Given this list of marker genes Ptprj, Trpv4, Csf1r, Cx3cl1 (NCBI Gene Id 58173), Ccr7, Slamf1, Tnfsf18, Mstn, C3ar1, Cmklr1, Mdk, Il34, Thbs1, Akirin1, Rarres2, Ccl2, Ccl21a, Ptk2 (NCBI Gene Id 14083), Csf1, Mapk3, C5ar1, Cxcl17, Mapk1, Trem1, Ccl5, here is a description of the gene set: Any process that increases the rate, frequency or extent of macrophage chemotaxis. Macrophage chemotaxis is the movement of a macrophage in response to an external stimulus. Mouse Gene Set: GOBP_POSITIVE_REGULATION_OF_MACROPHAGE_CHEMOTAXIS studied in species Mus musculus